The following is a description of a gene set: species: Homo sapiens part of: Fc epsilon receptor (FCERI) signaling Increase of intracellular calcium in mast cells is most crucial for mast cell degranulation. Elevation of intracellular calcium is achieved by activation of PLC-gamma. Mast cells express both PLC-gamma1 and PLC-gamma2 isoforms and activation of these enzymes leads to conversion of phosphatidylinositol 4,5-bisphosphate (PIP2) into inositol triphosphate (IP3) and diacylglycerol (DAG). The production of IP3 leads to mobilization of intracellular Ca+2, which later results in a sustained Ca+2 flux response that is maintained by an influx of extracellular Ca+2. In addition to degranulation, an increase in intracellular calcium concentration also activates the Ca2+/calmodulin-dependent serine phosphatase calcineurin. Calcineurin dephosphorylates the nuclear factor for T cell activation (NFAT) which exposes nuclear-localization signal sequence triggering translocation of the dephosphorylated NFAT-CaN complex to the nucleus. Once in the nucleus, NFAT regulates the transcription of several cytokine genes. Reactome Pathway: FCERI mediated Ca+2 mobilization, and this is the list of marker genes: VAV1, IGLV1-51, IGLV6-57, IGLC6, IGKV1-39, IGLC7, IGHV3-30, IGHV3-53, IGHV4-39, IGKV1D-16, NFATC2, IGKV1-33, IGLV3-1, IGKV2D-28, LAT, IGLV7-46, IGHV1-2, IGLV2-23, IGKV3-15, SOS1, IGLV4-69, IGLC3, ITK (NCBI Gene Id 3702), PPP3R1, IGKV3D-20, PLCG2, IGHV3-7, IGLV3-27, IGLV1-36 (NCBI Gene Id 28826), ITPR1, IGKV1D-33, IGHV3-48, IGKV2D-30, IGLV3-22, PPP3CA, IGHV4-59, PLCG1, AHCYL1, MS4A2, VAV2, IGKV1-12, IGLV, IGHV1-46, CALM1, IGLV4-3, GRAP2, IGKV1-17, IGLV1-44, IGLV2-14, IGLV10-54, IGHV2-5 (NCBI Gene Id 28457), TEC, IGLV2-33, IGLV3-16, IGLV8-61, IGHV3-11, IGLV1-40, NFATC3, FCER1G, IGKV1-16, IGKV1D-39, ITPR3, IGKV1D-12, IGKV2D-40, LYN, IGLV2-8, IGKC, IGHV3-13, TXK, IGKV2-30 (NCBI Gene Id 28919), IGLV4-60, IGLV5-37, IGLV2-18, PPP3CB, IGLV2-11, IGHV1-69, IGKV1-5, IGKV3-20, IGLV3-25, IGLV3-19, FCER1A, IGLV7-43, LCP2, IGLV11-55, NFATC1, IGKV5-2 (NCBI Gene Id 28907), IGHV4-34, IGKV2-29, IGHV, IGLV1-47, IGLC2, ITPR2, IGLV3-21, IGHV7-81, IGHV2-70, IGKV3-11, SHC1, IGHV3-9, IGKV4-1, IGHV3-23, IGLV5-45, IGHV3-33, BTK, SYK, IGLV3-12, IGLC1, VAV3, IGHE, GRB2, IGKV2-28